Given this list of marker genes Hgf, Gab1, Pik3ca (NCBI Gene Id 70742), Met, Pik3r1, Grb2, here is a description of the gene set: species: Mus musculus Mouse Gene Set: REACTOME_MET_ACTIVATES_PI3K_AKT_SIGNALING MET activates PI3K/AKT signaling